The following is a description of a gene set: Congenital generalized lipodystrophy studied in species Homo sapiens Human Gene Set: WP_CONGENITAL_GENERALIZED_LIPODYSTROPHY, and this is the list of marker genes: INS, PIK3CA, GPAT3, LPIN2, CAV1, LPIN3, CAVIN1, DGAT1, AGPAT2, LPIN1, GRB2, IRS1, ITGB4, DGAT2, HIF1A, AKT2, BSCL2, FYN